The following is a description of a gene set: Human Gene Set: REACTOME_THE_FATTY_ACID_CYCLING_MODEL The fatty acid cycling model species: Homo sapiens, and this is the list of marker genes: SLC25A27, SLC25A14, UCP1, UCP2, UCP3